Given this list of marker genes Inpp4b, Mtmr14, Pcyt1b, Pi4k2a, Pip4p1, Hadha, Pcyt1a, Slc44a2, Pla2g2f, Chka, Ddhd2, Alpi, Awat2, Pld6, Tmem86b, Pitpnb, Abhd3, Mtmr9, Pla2g2a, Ptdss1, Pla2g12a, Pla2g3, Csnk2b, Sacm1l (SAC1 suppressor of actin mutations 1-like (yeast)), Chkb, Mboat7, Tnfaip8l1, Cpne6 (NCBI Gene Id 12891), Pld2, Plekha8, Gpat2, Pik3r2, Slc44a3, Gpd1, Stard10, Pik3cb, Mtmr12, Pla2g2d, Ptpn13, Ptdss2, Arf1 (ADP-ribosylation factor 1), Pik3c2b, Mtmr4, Lipi, Mtmr2, Tnfaip8, Pik3c2a, Pcyt2, Plekha3, Pip5k1c, Cds1, Pla2g2e, Mtmr3, Slc44a4, Inppl1, Pla2g6, Tpte, Pla2r1, Pip4k2c, Agpat3, Pemt, Pip5k1a, Lclat1, Pik3r5, Inpp5e, Mtmr1, Tnfaip8l3, Mtmr7, Pla2g4d, Pitpnm2, Inpp5j, Mboat2, Pla2g4f (phospholipase A2, group IVF), Osbpl5, Pi4ka, Rab4a, Pitpnm3, Lpcat4, Synj2, Ocrl, Pik3c3, Pnpla6 (patatin-like phospholipase domain containing 6), Lpcat2, Dgat2l6 (diacylglycerol O-acyltransferase 2-like 6), Pnpla3, Pgp (phosphoglycolate phosphatase), Agpat4, Mfsd2a, Pnpla8, Agpat1, Gpam, Pla1a, Pla2g5, Pla2g1b, Fig4, Sbf1, Mtmr6, Osbpl10, Plbd1, Dgat2, Chpt1, here is a description of the gene set: Reactome Pathway: Phospholipid metabolism studied in species Mus musculus part of: Metabolism of lipids electronically inferred by orthology from the curated human pathway This event has been computationally inferred from an event that has been demonstrated in another species.<p>The inference is based on the homology mapping from PANTHER. Briefly, reactions for which all involved PhysicalEntities (in input, output and catalyst) have a mapped orthologue/paralogue (for complexes at least 75% of components must have a mapping) are inferred to the other species.